The following is a description of a gene set: Rhabdomyosarcoma species: Homo sapiens Human Gene Set: HP_RHABDOMYOSARCOMA, and this is the list of marker genes: FOXO1, MAD1L1, PTCH1, MDM2, BUB1, KEAP1, SLC22A18, PAX3, NBN, TRIP13, BUB1B, CEP57, NF1, TP53, CDKN2A, MLH1, CHEK2, HRAS, BUB3 (BUB3 mitotic checkpoint protein), PAX7, DICER1